Given this list of marker genes KAT5, TAF4, TWIST2, YY1, MTHFS, NCAPG2, ANKH, here is a description of the gene set: species: Homo sapiens Redundant eyelid skin pressing the eyelashes against the cornea and/or conjunctiva. Human Gene Set: HP_EPIBLEPHARON Epiblepharon